Given this list of marker genes RNU7-51P, SEL1L, RNU4-22P, LINC02296, LINC02330, STON2, LINC02328, GTF2A1, LINC02301, TSHR, PTPN21, LINC01467, DYNLL1P1, KCNK10, ZC3H14, HMGN2P2, ENSG00000305248, EIF3LP1, CAP2P1, DIO2-AS1, GALC, SHLD2P2, ENSG00000298659, FLRT2, ENSG00000284959, LINC02309, SPATA7, RNU6ATAC28P, GPR65, MTCYBP27, RPL9P6, LINC02305, UNGP3, RNU4-92P, LINC02311, LINC02316, LINC02308, NMNAT1P1, MTND4P33 (MT-ND4 pseudogene 33), GPRASP3P1, TTC8, MTND5P35, RNU6-835P, LINC01148, LINC02329, ENSG00000258419, ENSAP2, GTF2A1-AS1, LINC00911, FLRT2-AS1, RPL17P3, RNU6-976P, SNORA79, DIO2, CEP128, DYNLL1P2, HISLA, ENSG00000258538, MPPE1P1, LINC01147, EML5, EEF1A1P2, here is a description of the gene set: studied in species Homo sapiens Human Gene Set: chr14q31